Given this list of marker genes SLC34A3, ALPL, SLC17A6, ENPP3, UMOD, FGFR4, ABCC6, XPR1, SLC34A2, SLC34A1, PTH, SLC17A8, SFRP4, TMEM174, FGF23, GCM2, ENPP1, NHERF1, ANKH, SLC17A7, here is a description of the gene set: species: Homo sapiens Human Gene Set: GOBP_PHOSPHATE_ION_HOMEOSTASIS Any process involved in the maintenance of an internal steady state of phosphate ions within an organism or cell.